The following is a description of a gene set: Mouse Gene Set: MIR_672_3P from publication Chen Y, Wang X (PMID 31504780) Genes predicted to be targets of miRBase v22 microRNA mmu_miR_672_3p in miRDB v6.0 with MirTarget v4 prediction scores > 80 (high confidence targets). studied in species Mus musculus, and this is the list of marker genes: Cbx5, Zmym2, Lipo3, Gmps, Smarcad1, Stc2, Ubfd1, Gfral, Arhgap19, Slc39a6, Hand2, Dnajb9, Ube2o, Tceal7, Arnt2, Zmynd11, Klhl2, Akr1e1, Unc5c, Gap43, Zbtb34, Lck, Trip12, Uqcrh, Anxa10, Tbl1x, Eif4e, Srsf1, Tmcc1, Stk38, Lhfpl2, Hhip, Sftpa1, Ptchd4, Csmd2, Irx2, Amer2, Dusp18, Aak1, Ppp3r1, Zfp516, Itpripl2, Baz2a, Agl, Tenm3, Thsd7a, Sdha, Tub, Hmox1, Zcchc2, Luc7l3, Ptpn3, Mpped1, Chd5, Acvr2a, Rnf166, Synj1, Pira12, Xlr, Trim36, Fcgrt, Smpdl3a, Vmp1, Csrnp3, Edem1, Tasor, Pappa2, Fam53c, Mrpl18, Fxyd6, Hemgn, Zfp101, Larp4b, Setbp1, Ids, P2ry13, Wdfy2 (NCBI Gene Id 268752), Il1rap, Trim5, Prkab2, Phf21a, Sbno1, D16Ertd472e, Scrn1, Parp14, Lrpprc, Prr14l, Map3k7, Larp4, Zc3h12c, Cacna1b, Sash3, Qki, Cdon, Eaf1, Cd274, Umad1, Syk (NCBI Gene Id 20963), Pom121, Nptx1, Pnpo, Ets1, Strn4, Lin28b, Eif4b, Gcfc2, Klhl9, Frg2f1, Zcchc12, Blmh, Pou3f4, Marveld2, Slc11a2, Adissp, Kcna2, Hic2, Nab1, Alpk2, Slc25a40, Oas3, Crb3, Rock2, Hs2st1, Dusp6, Sec23b, Dkk1, Bcl2l1, Itgb3, Map3k1, Adnp, Snrk, Tnrc18, Dcbld2, Spock2, Smad4, Dtx4, Tnfrsf11a, Adpgk, Cds2, Rnf145, Enah, Rras, Lhfpl7, Evi5, Hook3, Fam133b, Prdm16, Ywhab, Pira2, Phc2, Atxn7l3, Jcad, Trim12c, Crebl2, Shq1, Mdga1, Alms1, Cmpk2, Ikbkg, Ddit4l, Ralgapa2, Rnf38, Lrp8, Kif3c, Smad3, Phc3, Nip7, Hoxc6, Rnf152, Zfp462, Stx1b, Kifc3, Usp15, Ep300, Tmx1 (NCBI Gene Id 72736), Csgalnact1, Bpifc, Terb2, Igf1r, Cenpf, Fam219a, Ube2d2a, Ptpre, Efr3a, Arid1b, Arhgap26, Vps50, Ccl28, Cbl, Prpf19, Spindoc, Zfp580, Gtpbp1 (NCBI Gene Id 97981), Hmg20a, Rasa1, Gpx5, Max, Camta1, Bahcc1, Igsf9b, Baz2b, Ubl3, Prrg3 (proline rich Gla (G-carboxyglutamic acid) 3 (transmembrane)), Rab11fip4, C2cd2l, Mrps17, Mmgt1, Enc1, Lonrf3, Klf11 (NCBI Gene Id 52503), Foxk1, Sv2a, Dnajc25, Mip, Klf6, Unk, Ttll7, Slc4a7, 1700028K03Rik, Lmx1a, Gga3, Sbk3, Zpld1 (zona pellucida like domain containing 1), Ndrg3, Plod2, Scube2, Mga, Cpsf6, Crispld2, Pappa, Nedd9, Dcp2, Ms4a6d, Kif13a, Dlg2, Fahd1, Zkscan8, Gria3, Cst6, Ppp1r9a, Usp13, Casd1, Ing2, Tns3, Kif3b, Slc22a15 (NCBI Gene Id 99953), Foxk2, Il10ra, Cfap418, Lysmd2, Septin3, Ogfod1, Ssr3, Ctcf, Dpp10, Nucb1, Crkl, Ube2h, Sh2d4a, Mob3b, Prkx, Tanc2, Zeb2 (zinc finger E-box binding homeobox 2), Hps3, N4bp2l2 (NEDD4 binding protein 2-like 2), Rad51c, Rps6ka2, Npepps, Rab3c, Limk1, Zfp704, Teddm2, R3hdm4, Bicd2, Cpeb1, Xrn2, Mnt, Zbtb18, Mrfap1, Ddah1, Creb1 (cAMP responsive element binding protein 1), Iqsec1, Map2k7, Tbc1d4, Msi2, Pitpnm3, Crmp1, Sh3rf1, Ccng2, B230219D22Rik, Wnt9a, Kirrel1, Prkd1, Ptprb, Itgav, Dhcr24, Mast3, Prkag2, Msrb3, Kcnb1, Ssbp2, Ints10, Cckar, Slc36a1, Atp5if1, Spin1, Ets2